The following is a description of a gene set: Mouse Gene Set: GOBP_MRNA_3_END_PROCESSING Any process involved in forming the mature 3' end of an mRNA molecule. species: Mus musculus, and this is the list of marker genes: Cpsf3, Tent2, Leo1, Cstf2, Ssu72, Cstf2t, Mblac1, Cpeb1, Rprd1b, Cstf1 (NCBI Gene Id 99067), Ncbp2, Cpsf6, Zcchc8, Papola, Cdc73, Ncbp1, Zfp473, Ahcyl1, Lsm11, Zfp36l1, Rprd2, Fip1l1, Tut1, Cpsf7, Rbfox2, Slbp, Tent4b, Dhx36, Angel2, Cpsf2, Pabpn1, Cstf3, Wdr33, Paf1, Zc3h3, Lsm10, Nudt21, Pcf11, Clp1, Ccnb1, Pabpc2, Ythdc1, Rprd1a, Cdk9